Given this list of marker genes Angpt2, Edn1, Cxadr, F11r, Ajuba, Lepr, Nectin2, Adm, Tnc, Tgfb2, Spry1, Unc5b, Cd200, Pim1, Esam, Pdgfb, Tgfb3, Eng, Thbs1, Hoxb5, here is a description of the gene set: from publication Clasper S, Royston D, Baban D, Cao Y, Ewers S, Butz S, Vestweber D, Jackson DG (PMID 18794116) studied in species Mus musculus Invasion of lymphatic vessels is a key step in the metastasis of primary tumors to draining lymph nodes. Although the process is enhanced by tumor lymphangiogenesis, it is unclear whether this is a consequence of increased lymphatic vessel number, altered lymphatic vessel properties, or both. Here we have addressed the question by comparing the RNA profiles of primary lymphatic endothelial cells (LEC) isolated from the vasculature of normal tissue and from highly metastatic T-241/vascular endothelial growth factor (VEGF)-C fibrosarcomas implanted in C57BL/6 mice. Our findings reveal significant differences in expression of some genes (i.e., >or=2-fold up- or down-regulated, P <or= 0.05) that code for a variety of proteins including components of endothelial junctions, subendothelial matrix, and vessel growth/patterning. The tumor LEC profile, validated by immunohistochemical staining, is distinct from that of normal, inflammatory cytokine, or mitogen-activated LEC, characterized by elevated expression of such functionally significant molecules as the tight junction regulatory protein endothelial specific adhesion molecule (ESAM), the transforming growth factor-beta coreceptor Endoglin (CD105), the angiogenesis-associated leptin receptor, and the immunoinhibitory receptor CD200, and reduced expression of subendothelial matrix proteins including collagens, fibrillin, and biglycan. Moreover, we show similar induction of ESAM, Endoglin, and leptin receptor within tumor lymphatics in a series of human head and neck and colorectal carcinomas, and uncover a dramatic correlation between ESAM expression and nodal metastasis that identifies this marker as a possible prognostic indicator. These findings reveal a remarkable degree of phenotypic plasticity in cancer lymphatics and provide new insight into the processes of lymphatic invasion and lymph node metastasis. Selected genes up-regulated during invasion of lymphatic vessels during metastasis. Mouse Gene Set: CLASPER_LYMPHATIC_VESSELS_DURING_METASTASIS_UP